Given this list of marker genes FGF8, LRRFIP1 (LRR binding FLII interacting protein 1), STAT5B, FGFR1, BCR, CEP43, FGF2, STAT5A, FGFR1OP2 (NCBI Gene Id 378428), MYO18A, FGF4, BAG4, GRB2, STAT1, FGF9 (fibroblast growth factor 9), PIK3CA, FGF6, FGF17, CPSF6, FGF23, FGF1, GAB2, ZMYM2, CNTRL, CUX1, TRIM24, STAT3, FGF20 (NCBI Gene Id 26281), ERLIN2, FGF5, PIK3R1, here is a description of the gene set: Reactome Pathway: FGFR1 mutant receptor activation studied in species Homo sapiens part of: Signaling by FGFR1 in disease The FGFR1 gene has been shown to be subject to activating mutations, chromosomal rearrangements and gene amplification leading to a variety of proliferative and developmental disorders depending on whether these events occur in the germline or arise somatically. Many of the resulting mutant FGFR1 proteins can dimerize and promote signaling in a ligand-independent fashion, although signal transduction may still be amplified in the presence of ligand.